Given this list of marker genes KIF14, ADGRG6, IGF2, CHUK, CHRNG, MYH3, LMX1B (LIM homeobox transcription factor 1 beta), here is a description of the gene set: Human Gene Set: HP_ANTECUBITAL_PTERYGIUM Antecubital pterygium Pterygium affecting the elbow. This is a cutaneous web that can lead to severe flexion contracture of the elbow joint. Antecubital pterygium can be unilateral, bilateral, symmetric, or asysmmetric. species: Homo sapiens